Given this list of marker genes GRIP1, DRC3, RHOA, ARG2, WDR41, PER1, MTOR (NCBI Gene Id 2476), RMI1, COPS4, FBXL13, IFT25, COPS2, PARD6B, RAB39B, ARMC8, LIMK1, TOP3A, BCL2L11, PPP1R14A, IQCD, IL1B, COPS7A, IFT70B, NFKB1, IFT22, MIGA1, GPR85, BIRC2, CREB1, RB1CC1, MPRIP, RAB10, IFT52, JUN, LDHA, IFT57, NR1H2, HES6, RPTOR, WDR26, MYO15A, C9orf72 (NCBI Gene Id 73205), PRDM1, RAI1, LLGL1, RMI2, RMND5A, WWTR1, EFCAB2, ETV5, IFT20, GPS1, MLST8, CRY1 (cryptochrome circadian regulator 1), FHOD1, MYO16, PCK1, ULK1, RASD1, PEMT, IFT81, CLTB, PTEN, APBB1, GDI2, COPS8, TCTE1, TFEB, PRKAA1, CDK1 (cyclin dependent kinase 1), TOLLIP (toll interacting protein), PARD3, CFL2, COPS6, RNF41, MIGA2, TP53, TNFRSF13B, APP, BAX, PPP1R12A, CRY2, FLCN, IFT27, CLOCK, BCL6, IFT172, MIR33B, GAS8, SMCR8, FOXA1, HBP1, DRC7, IFT46, CCDC65, ATG101, IFT88, MED9, RRAGA, FOXA2 (forkhead box A2), FERD3L, FLII, ROCK1, IQCA1, SREBF1, MAEA, IQCG, IFT56, STAT3, ITPK1, BLM, IFT74, ATG13, NR1H3, RELA, RAB8A, G6PC1, SHMT1, TFE3, COPS5, DRC1, PRKCI, IRF8, PRKAB1, IFT80, NT5M, MYC, FNIP2, CLTC, TRAF3IP1, DRG2, CLUAP1, CLTA, USP8, TOM1L2, COPS3, MYD88, MYH2, SMCR5, MAP3K14, RANBP9, FNIP1 (NCBI Gene Id 96459), MIEF2, GID4, MKLN1, CLEC16A, PLD6, ATPAF2, TNF, TLR4, YAP1, PRKAG2, SMCR2, ALKBH5, BMAL1 (basic helix-loop-helix ARNT like 1), DENR, TNFSF13, PRKN (NCBI Gene Id 8004), CARM1, here is a description of the gene set: species: Homo sapiens Smith-Magenis and Potocki-Lupski syndrome copy number variation Human Gene Set: WP_SMITHMAGENIS_AND_POTOCKILUPSKI_SYNDROME_COPY_NUMBER_VARIATION